The following is a description of a gene set: studied in species Mus musculus Any process that stops, prevents, or reduces the frequency, rate or extent of DNA-dependent DNA replication. Mouse Gene Set: GOBP_NEGATIVE_REGULATION_OF_DNA_TEMPLATED_DNA_REPLICATION, and this is the list of marker genes: Gmnn, Tipin, Fbxo5, Dynll1, Cdt1, Atg7, Lig3, Timeless